Given this list of marker genes RNFT2 (NCBI Gene Id 84900), FIG4, IFT27, PI4KB, ARHGAP29, PITPNA, PEX1, EPHB2, FGFR3, SCAF11, SRGAP2, ST3GAL1, GNAI2, CELSR2, DEPP1, SLC38A10, EP300 (E1A binding protein p300), ITPR3, MAT2A, C1orf216, DIO1, NUP210, EPHB4, PDIA4, RBBP6, SHMT1, ATP7B, UFD1, HOXB5, ARHGAP35, PMPCA (NCBI Gene Id 23203), PCDH7, AQR, SLC5A6, UBR2, CLSTN1 (calsyntenin 1), LIG1, LRP5, CTNS (NCBI Gene Id 1497), SARM1, STK11, GYS1, FSCN1, PODXL, MEN1, ADCY9, JCAD, HYOU1, TNFAIP2, SLITRK5, CAPN1, BCL11A, PARP4, ABCB6, PPP2R5B, INTS1, OCEL1, POLR2A, CHD4, SORL1, ATG2A (NCBI Gene Id 23130), MBTPS1, MGAT5, TCF3, ULK1, MICA, GLDC, DAG1, ADAM17, IGSF3, ADCY3, TFRC, MARCHF2, CLEC16A, CTDSP2, MYO9B, AMOT, SEC16A, CAD, NPRL2, KDELR2, OBSL1, TRIM16, RIMS3, FADS2, ARHGAP4, C4B, AP1G2, CBR1, ULK4P3, PLEC, ITPR1, TRAPPC12, PNPLA6, GPC1, POR, PDE8A, ATR, ESYT1, PSME3, KHK, LASP1, SLC6A8, ATP2A2, SEC14L1, DOP1B, NPTX1, GNS, HNRNPDL, MLEC, POLG, FANCA, AGRN, MAPKAPK3, BRCA1, GAMT, IMPA2, P3H3, ALDH1B1, GLB1L2, ITGA6, PRMT2, PIM2, GM2A, RBM14, SKIC2, TUBB4A, TCF7 (NCBI Gene Id 6932), FDXR, COL2A1, FZD2, DDB2, FBN2, GGA2, SLC37A4, CCNE1, SEPTIN9, MKI67, GALK1 (galactokinase 1), ZFC3H1, POLA2, KANK1, SULT1A2, DHX9, NHERF1, UNC50, GPLD1, XPC, NISCH (nischarin), HSPA12A, ERBB2, TMEM63A, MYO10, TCF25, HEXIM1, IGFBP5, MAPRE2, ABHD14A, CILK1, PTK7, PPARD, H2AZ2, SLC1A5, UBAP2L, MYOM2, PCYT2, SBF1, FLNC, ABCA2, ITSN1 (NCBI Gene Id 6453), ABCC10, VCAN, ITGA7, MAGED1 (NCBI Gene Id 9500), COL4A6, FADS1, AHNAK, BAG1, PLXNB2, SFRP1, MAP4, ABCB9, ITGB5, TSPOAP1, NAGA, NCDN, DHCR24 (NCBI Gene Id 9800), TBC1D9B, FTSJ1, IGF2R, CSPG5, SUOX, GGCX, STC1, PREP, ARHGEF10, EDRF1, GLB1, TXNIP, PRKCD, PRPSAP1, ITPKB, SPTBN2, MSH6, NOMO1, RAD54L, SCO2, MAP2K3, METTL13, TBC1D2B, RPL3, REEP2, ENPP2, NDUFAF1, PLCG2, ZBED1, PSEN2, SLC7A5, NUP98, SV2A, C10orf95-AS1, NOTCH3, HIRA, INSIG1, GRHPR, SLC27A2, RRBP1, ABR, PLTP, CDK9, FLNA, IDH1, STK25, RGS16 (regulator of G protein signaling 16), DHCR7, SERPINE2, FAM114A1, TBCD, SYNM, ZCCHC24, LAMB2, SQLE, DBN1, LAMA5, ADD2, PTPRF, WFS1, DICER1 (dicer 1, ribonuclease III), KDM5C, B4GAT1, TYK2, DNAL4, CD9, MYC, STEAP2-AS1, BLTP2, LRP4, SLC29A1, ENO2, PRAME, EP400, TRIM27, OGDH, THRA, LPCAT1, PFAS, ARHGEF17, ATXN1, TMT1A, ERCC5, IPO13, COL4A2, SELENBP1, FUCA1, BDH1, GTF2I, here is a description of the gene set: from publication DeBiasi RL, Clarke P, Meintzer S, Jotte R, Kleinschmidt-Demasters BK, Johnson GL, Tyler KL (PMID 12885910) studied in species Homo sapiens Human Gene Set: DEBIASI_APOPTOSIS_BY_REOVIRUS_INFECTION_DN Reoviruses are a leading model for understanding cellular mechanisms of virus-induced apoptosis. Reoviruses induce apoptosis in multiple cell lines in vitro, and apoptosis plays a key role in virus-induced tissue injury of the heart and brain in vivo. The activation of transcription factors NF-kappaB and c-Jun are key events in reovirus-induced apoptosis, indicating that new gene expression is critical to this process. We used high-density oligonucleotide microarrays to analyze cellular transcriptional alterations in HEK293 cells after infection with reovirus strain T3A (i.e., apoptosis inducing) compared to infection with reovirus strain T1L (i.e., minimally apoptosis inducing) and uninfected cells. These strains also differ dramatically in their potential to induce apoptotic injury in hearts of infected mice in vivo-T3A is myocarditic, whereas T1L is not. Using high-throughput microarray analysis of over genes, we identified differential expression of a defined subset of genes involved in apoptosis and DNA repair after reovirus infection. This provides the first comparative analysis of altered gene expression after infection with viruses of differing apoptotic phenotypes and provides insight into pathogenic mechanisms of virus-induced disease. Genes down-regulated in HEK293 cells (embryonic kidney) at 6 h, 12 h or 24 h after infection with reovirus strain T3A (known as a strong inducer of apoptosis).